Given this list of marker genes Hsp90aa1, Bag4, Tomm5, Tomm20l, Romo1, Bid, Hspa4, Bag3, Timm21, Timm50, Timm23, Immp1l, Dnajc15, Ndufa13, Tomm22, Hspa1l, Bcap31, Siah3, Dusp18, Pmpcb, Lrrk2, Mipep, Gfer, Pink1 (PTEN induced putative kinase 1), Dnlz, Tomm34, Ywhaz, AU015836, Bnip3l, Samm50 (NCBI Gene Id 68653), Pam16, Gsk3a, Trmt10b, Ppp2r2b, Timm9, Agk, Fbxw7, Fis1, Srebf1, Mtch2 (mitochondrial carrier 2), Timm44, Hspd1, Tomm40, Cdkn2a, Tomm70a, Mff, Tomm20, Timm17b, Mfn2, Mterf4, Fbxo7, Adcy10, Sirt4, Aifm1, Tomm7, Atp5if1, Timm8a1, Dnajc19, Pdcd5, Timm10, Mgarp, Timm13, Timm29, Ptpn5, Aip, Tomm40l, Grpel1, Immp2l, Timm17a, Grpel2, Timm22, Gdap1, Chchd4, Mtch1, 4930550C14Rik, Parl, Nol3 (nucleolar protein 3 (apoptosis repressor with CARD domain)), Dusp21, Pmpca, Prkaa1, Pdcd5-ps, here is a description of the gene set: The process of directing proteins towards and into the mitochondrion, usually mediated by mitochondrial proteins that recognize signals contained within the imported protein. species: Mus musculus Mouse Gene Set: GOBP_PROTEIN_TARGETING_TO_MITOCHONDRION